Given this list of marker genes Ypel3, Ms4a4c, Srsf5, Cirbp, Uqcrfs1, Slc50a1, Ten1, Akr1a1, Bcl7c, here is a description of the gene set: from publication Cui A, Huang T, Li S, Ma A, Pérez JL, Sander C, Keskin DB, Wu CJ, Fraenkel E, Hacohen N (PMID 38057668) Mouse Gene Set: CUI_B_CELL_TSLP_RESPONSE_UP Genes positively differentially expressed in cell type: B cell upon treatment with cytokine: TSLP in mouse lymph nodes in vivo. Cytokines mediate cell-cell communication in the immune system and represent important therapeutic targets. A myriad of studies have highlighted their central role in immune function, yet we lack a global view of the cellular responses of each immune cell type to each cytokine. To address this gap, the authors created the Immune Dictionary, a compendium of single-cell transcriptomic profiles of more than 17 immune cell types in response to each of 86 cytokines (>1,400 cytokine-cell type combinations) in mouse lymph nodes in vivo. A cytokine-centric view of the dictionary revealed that most cytokines induce highly cell-type-specific responses. For example, the inflammatory cytokine interleukin-1β induces distinct gene programmes in almost every cell type. A cell-type-centric view of the dictionary identified more than 66 cytokine-driven cellular polarization states across immune cell types, including previously uncharacterized states such as an interleukin-18-induced polyfunctional natural killer cell state. species: Mus musculus